Given this list of marker genes Cand1, Atp6v1e1, Atp6v0d2, Ftmt, Trf, Atp6v0e2, Atp6v1c2, Tcirg1, Atp6v0b, Ftl2-ps, Uba52rt, Atp6v1h, Ubc, Tfr2, Atp6v1c1, Atp6v0c, Atp6v1d, Hfe, Atp6v1g2, Uba52, Atp6v1b1, Atp6v0a2, Atp6ap1, Lcn2, Skp1, Atp6v0a4, Atp6v1a, Atp6v1b2 (NCBI Gene Id 97492), Mcoln1, Aco1, Atp6v1f, Slc22a17, Atp6v1g1, Heph, Ubb, Cul1, Steap3, Slc46a1, Steap4, Cp, Nedd8, Atp6v1g3, Fth1, Atp6v1e2, Rps27a, Fbxl5, Hmox1, Atp6v0a1, Tfrc, Cybrd1, Flvcr1 (feline leukemia virus subgroup C cellular receptor 1), Atp6v0d1, Ireb2, Hmox2, Slc11a2, Slc40a1, Atp6v0e, here is a description of the gene set: Iron uptake and transport Mouse Gene Set: REACTOME_IRON_UPTAKE_AND_TRANSPORT species: Mus musculus